Given this list of marker genes Tas2r120, Tas2r129, Tas1r2, Tas2r131, Ffar4, Tas2r102, Tas2r116, Pkd2l1, Tas2r139, Tas2r143, Tas2r136, Tas2r125, Tas2r104, Tas1r1, Tas2r130, Tas2r124, Tas2r123, Tas2r118, Tas2r122, Tas2r115, Tas2r140, Tas2r108, Tas2r113, Tas2r138, Tas2r106, Tas2r114, Tas2r137, Tas2r135, Tas2r109, Pkd1l3, Tas2r105, Tas2r121, Tas2r134, Tas2r119, Tas2r107, Tas1r3, Tas2r117 (taste receptor, type 2, member 117), Tas2r144, Tas2r126, Tas2r110, Tas2r103, here is a description of the gene set: Combining with soluble compounds to initiate a change in cell activity. These receptors are responsible for the sense of taste. Mouse Gene Set: GOMF_TASTE_RECEPTOR_ACTIVITY species: Mus musculus